Given this list of marker genes Nr3c1, Cd180, Clk4, Arnt, Zfa-ps (NCBI Gene Id 22639), Rnf2, Il6st, Srsf1, Cybb, Rnf13, Lyst, Pknox1, Mxd1, Mtmr1, Mapk9, Wrn, Stat5b, Ncf1, Baz1b, Sorl1, Hivep2 (NCBI Gene Id 15273), Papola, Tfdp1, Tmpo, Nvl, Pld1, Pik3r1, Ddb1, Cand1, Adam10 (NCBI Gene Id 67314), Pik3cd, Hcfc1, Itgal, Matr3, Ptprj, Hipk1, Foxm1, Rab10, Ceacam2, Sf3b1, Eif4g1, Klrk1, Ssr3, Slfn3, Syk, Pstpip2, Snx2, Adar, Mapkapk2, Pim1, Cd44, Ikzf1, Incenp, Ercc2, Sla, Ap1g1, Kpna3 (karyopherin subunit alpha 3), Zfp422, Pitpnb, Tram1, here is a description of the gene set: species: Mus musculus Genes whose expression in bone marrow samples correlated inversely with increased levels of serum IL5. Interleukin-5 (IL-5) is a hematopoietic differentiation factor that promotes the development of mature eosinophils from progenitors in bone marrow. We present a multifactorial microarray study documenting the transcriptional events in bone marrow of wild-type and IL-5-deficient mice at baseline and in response to infection with Schistosoma mansoni. The microarray data were analyzed by a 4-way subtractive algorithm that eliminated confounding non-IL-5-related sequelae of schistosome infection as well as alterations in gene expression among uninfected mice. Among the most prominent findings, we observed 7- to 40-fold increased expression of transcripts encoding the classic eosinophil granule proteins (eosinophil peroxidase, major basic protein, the ribonucleases) together with arachidonate-15-lipoxygenase and protease inhibitor plasminogen activator inhibitor 2 (PAI-2), in the IL-5-producing, infected wild-type mice only. This was accompanied by increased transcription of genes involved in secretory protein biosynthesis and granule-vesicle formation. Interestingly, we did not detect increased expression of genes encoding eosinophil-related chemokine receptors (CCR1, CCR3) or members of the GATA or CCAAT/enhancer binding protein (C/EBP) transcription factor families. These data suggest that the IL-5-responsive progenitors in the mouse bone marrow are already significantly committed to the eosinophil lineage and that IL-5 promotes differentiation of these committed progenitors into cells with recognizable and characteristic cytoplasmic granules and granule proteins. Mouse Gene Set: BYSTROEM_CORRELATED_WITH_IL5_DN from publication Byström J, Wynn TA, Domachowske JB, Rosenberg HF (PMID 14525773)